The following is a description of a gene set: from publication Hoek KL, Samir P, Howard LM, Niu X, Prasad N, Galassie A, Liu Q, Allos TM, Floyd KA, Guo Y, Shyr Y, Levy SE, Joyce S, Edwards KM, Link AJ (PMID 25706537) Genes up-regulated in T cell 7d vs 0d in adults after exposure to 2011-2012 trivalent inactivated vaccine (A/California/7/09 (H1N1), A/Perth /16/2009 (H3N2), B/Brisbane/60/2008), time point 7D. Comment: Up-regulated DE RNA transcripts (up >= 1.5x) shared between both TIV-vaccinated donors species: Homo sapiens Human Gene Set: HOEK_T_CELL_2011_2012_TIV_ADULT_7DY_UP Systems biology is an approach to comprehensively study complex interactions within a biological system. Most published systems vaccinology studies have utilized whole blood or peripheral blood mononuclear cells (PBMC) to monitor the immune response after vaccination. Because human blood is comprised of multiple hematopoietic cell types, the potential for masking responses of under-represented cell populations is increased when analyzing whole blood or PBMC. To investigate the contribution of individual cell types to the immune response after vaccination, we established a rapid and efficient method to purify human T and B cells, natural killer (NK) cells, myeloid dendritic cells (mDC), monocytes, and neutrophils from fresh venous blood. Purified cells were fractionated and processed in a single day. RNA-Seq and quantitative shotgun proteomics were performed to determine expression profiles for each cell type prior to and after inactivated seasonal influenza vaccination. Our results show that transcriptomic and proteomic profiles generated from purified immune cells differ significantly from PBMC. Differential expression analysis for each immune cell type also shows unique transcriptomic and proteomic expression profiles as well as changing biological networks at early time points after vaccination. This cell type-specific information provides a more comprehensive approach to monitor vaccine responses., and this is the list of marker genes: H3C1, LINC01063, NPIPB12, PI4KAP2, SIGLEC17P, ANKRD30BL, CASP5, CCDC34 (coiled-coil domain containing 34)